Given this list of marker genes SECTM1 (secreted and transmembrane 1), CKMT1B, QPCT, MELTF, XDH, HSD17B12, CCDC88B, ATP6V1B1, ATP6V1C2, GJB2, ITPR2, LPCAT1, PIGR, RPS6KL1, RFTN2 (raftlin family member 2), C10orf90, GGT5, ALDH1A3, ASIC1, FOXI1 (NCBI Gene Id 2299), LALBA, GNE (NCBI Gene Id 81868), TSPAN33, RASGEF1C, SLC13A2, CD14, CTSC, HIVEP3, C1QTNF1, PDZK1IP1, FOLR1, SLC28A3, CYP24A1, HAPLN3, RASAL1, CXCR4, NCALD, ELF5, LBP, NOXO1, C3, KIT, CSN3, IL4I1, PLB1, TNFAIP2, S100A8, ANPEP, SORBS2, CSN2, DAPP1, GALNT15, SLC34A2, CLDN1, IL15, WFDC3 (WAP four-disulfide core domain 3), ACSL1, BBOX1, here is a description of the gene set: from publication Lim E, Wu D, Pal B, Bouras T, Asselin-Labat ML, Vaillant F, Yagita H, Lindeman GJ, Smyth GK, Visvader JE (PMID 20346151) Human Gene Set: LIM_MAMMARY_LUMINAL_PROGENITOR_UP Genes consistently up-regulated in mammary luminal progenitor cells both in mouse and human species. INTRODUCTION: Molecular characterization of the normal epithelial cell types that reside in the mammary gland is an important step toward understanding pathways that regulate self-renewal, lineage commitment, and differentiation along the hierarchy. Here we determined the gene expression signatures of four distinct subpopulations isolated from the mouse mammary gland. The epithelial cell signatures were used to interrogate mouse models of mammary tumorigenesis and to compare with their normal human counterpart subsets to identify conserved genes and networks.METHODS: RNA was prepared from freshly sorted mouse mammary cell subpopulations (mammary stem cell (MaSC)-enriched, committed luminal progenitor, mature luminal and stromal cell) and used for gene expression profiling analysis on the Illumina platform. Gene signatures were derived and compared with those previously reported for the analogous normal human mammary cell subpopulations. The mouse and human epithelial subset signatures were then subjected to Ingenuity Pathway Analysis (IPA) to identify conserved pathways.RESULTS: The four mouse mammary cell subpopulations exhibited distinct gene signatures. Comparison of these signatures with the molecular profiles of different mouse models of mammary tumorigenesis revealed that tumors arising in MMTV-Wnt-1 and p53-/- mice were enriched for MaSC-subset genes, whereas the gene profiles of MMTV-Neu and MMTV-PyMT tumors were most concordant with the luminal progenitor cell signature. Comparison of the mouse mammary epithelial cell signatures with their human counterparts revealed substantial conservation of genes, whereas IPA highlighted a number of conserved pathways in the three epithelial subsets.CONCLUSIONS: The conservation of genes and pathways across species further validates the use of the mouse as a model to study mammary gland development and highlights pathways that are likely to govern cell-fate decisions and differentiation. It is noteworthy that many of the conserved genes in the MaSC population have been considered as epithelial-mesenchymal transition (EMT) signature genes. Therefore, the expression of these genes in tumor cells may reflect basal epithelial cell characteristics and not necessarily cells that have undergone an EMT. Comparative analyses of normal mouse epithelial subsets with murine tumor models have implicated distinct cell types in contributing to tumorigenesis in the different models. species: Mus musculus